Given this list of marker genes Kcnj8, Kcns1, Kcnc2, Hcn1 (hyperpolarization activated cyclic nucleotide gated potassium channel 1), Kcna4, Kcng4, Kcnip4, Kcnk1, Kcnb1, Kcna7, Grik4, Kcns3, Amigo1, Hcn4, Kcnj9, Grik5, Dpp6, Kcnd3, Kcna10, Lrrc55, Kcnmb2, Slc5a3, Lrrc52, Sumo1, Kcnmb4, Grik1, Kcnq4, Kcnj6, Kcnv1, Kcnq3, Kcnj11, Dlg2, Kcnd2, Cttn, Kcnc3, Kcnk4 (NCBI Gene Id 16528), Kcng1, Kcne5, Abcb8, Kcnmb3, Kcng2, Kcna3, Kcnf1, Ccdc51, Abcc8, Kcnip2, Lrg1, Kcns2, Pde4d, Dpp10, Lrrc26, Kcnab3, Kcnc4, Kcne1, Kcnip1, Kcne4, Kcnj5, Abcc9, Dlg4, Kcnh5, Kcna1, Kcnq1, Kcnab2, Kcna5, Hcn2, Kcnh1, Kcnv2, Calm1, Kcnq2, Kcnj2, Hcn3, Calm2, Akap9, Kcnab1, Stx1a, Kcna6, Kcnma1, Kcnq5, Grik2, Kcne2, Kcnk2, Kcnd1, Gria4, Vamp2, Kcnip3, Kcnj3, Kcnmb1, Calm3, Lrrc38, Grik3, Kcnh2, Kcne3, Kcng3, Kcnc1, Cntnap2, Kcnb2 (NCBI Gene Id 98741), Snap25, Kcna2, here is a description of the gene set: studied in species Mus musculus An ion channel complex through which potassium ions pass. Mouse Gene Set: GOCC_POTASSIUM_CHANNEL_COMPLEX